The following is a description of a gene set: Mouse Gene Set: GOBP_CELL_SUBSTRATE_JUNCTION_ORGANIZATION A process that is carried out at the cellular level which results in the assembly, arrangement of constituent parts, or disassembly of a cell-substrate junction. A cell-substrate junction is a specialized region of connection between a cell and the extracellular matrix. species: Mus musculus, and this is the list of marker genes: Myoc, Rcc2, Itgb1bp1, Nrp1, Lamc1, Cfl1, Fn1, Coro2b, Actn2, Fam107a, Fmn1, Cttn, Efna5, Tsc1, Vegfa, Clasp1, Actn3, Grem1, Src, Bcr, Dapk3, Pdpk1, Ptpra, Slk, Epha3, Rock1, Hrg, Tln1, Ptprj, Arhgap6, Limch1, Apod, Ptk2b, Phldb2, Col16a1, Camsap3, Wdpcp, S100a10, Epb41l5, Tesk2, Tns1 (NCBI Gene Id 98418), Smad3, Gpm6b, Acvrl1, Clasp2, Ston1, Rhod, Peak1, Bcl2, Iqgap1, Sdc4, Lama3, Sorbs1, Taok2, Ptk2, Actn1, Itgb4 (integrin beta 4), Actg1, Ptprk, Coro1c, Rab8b (RAB8B, member RAS oncogene family), Dusp3, Myh9, Rac1, Itga5, Prickle1, Dlc1, Itgb3, Itga2, Wnt4, Poldip2, Col17a1, Vcl, Mapre2, Map4k4, Pik3r1 (phosphoinositide-3-kinase regulatory subunit 1), Thsd1, Lims1, Thy1, Dst, Fermt2, Pxn, Arf6, Kdr, Dusp22, Rhpn1, Lamtor2, Ptpn11, Dmtn, Mmp14, Lrp1, Cdh11, Abl1 (NCBI Gene Id 98922), Macf1, Tek, Itgav, Whamm, Pip5k1a, Ajuba, Plec, Ppm1f, Enpp2, Pten, Iqsec1 (NCBI Gene Id 79407), Ldb1